Given this list of marker genes GRM4 (glutamate metabotropic receptor 4), FCGR2A, MVK, ADCYAP1, CD8B, FEV, SLC30A3, RING1, VAV1, FANCC, SLC18A1, SLC2A4, TEC, CHIC1, IFNA21, PTPRU, KRT83, MPP2, DGCR6, AVPR1B, ZNF8, CHRM5, HMGA2, MYH7, CCR9, NDUFA1, APOC3, TMEM106A, NRF1 (nuclear respiratory factor 1), PDE6B, SLC17A2, MADD, here is a description of the gene set: species: Homo sapiens Neighborhood of TEC tec protein tyrosine kinase in the GCM expression compendium Human Gene Set: GCM_TEC Neighborhood of TEC